The following is a description of a gene set: This event has been computationally inferred from an event that has been demonstrated in another species.<p>The inference is based on the homology mapping from PANTHER. Briefly, reactions for which all involved PhysicalEntities (in input, output and catalyst) have a mapped orthologue/paralogue (for complexes at least 75% of components must have a mapping) are inferred to the other species. Reactome Pathway: Type I hemidesmosome assembly part of: Cell junction organization electronically inferred by orthology from the curated human pathway studied in species Mus musculus, and this is the list of marker genes: Krt14, Cd151, Col17a1